The following is a description of a gene set: Genes up-regulated in peripheral blood mononuclear cells (PBMC) from patients with type 1 diabetes at the time of diagnosis versus those with type 2 diabetes at the time of diagnosis. Objective: We hypothesized that type 1 diabetes (T1D) is accompanied by changes in gene expression in peripheral blood mononuclear cells (PBMCs) due to dysregulation of adaptive and innate immunity, counterregulatory responses to immune dysregulation, insulin deficiency and hyperglycemia. Research Design and Methods: Microarray analysis was performed on PBMCs from 43 patients with newly diagnosed T1D, 12 patients with newly diagnosed type 2 diabetes (T2D) and 24 healthy controls. One and four month follow-up samples were obtained from 20 of the T1D patients. Results: Microarray analysis identified genes differing in expression between newlydiagnosed T1D patients and controls at a false discovery rate of 0.05. Changes in expression of interleukin-1β (IL1B), early growth response gene 3 (EGR3), and prostaglandin-endoperoxide synthase 2 (PTGS2) resolved within four months of insulin therapy and were also observed in T2D suggesting that they resulted from hyperglycemia. With use of a knowledge base, 81/genes could be placed within a network of interrelated genes with predicted functions including apoptosis and cell proliferation. IL1B and the MYC oncogene were the most highly-connected genes in the network. IL1B was highly overexpressed in both T1D and T2D, whereas MYC was dysregulated only in T1D. Conclusion: T1D and T2D likely share a final common pathway for beta cell dysfunction that includes secretion of interleukin-1β and prostaglandins by immune effector cells, exacerbating existing beta cell dysfunction, and causing further hyperglycemia. The results identify several targets for disease-modifying therapy of diabetes and potential biomarkers for monitoring treatment efficacy. studied in species Homo sapiens from publication Kaizer EC, Glaser CL, Chaussabel D, Banchereau J, Pascual V, White PC (PMID 17595242) Human Gene Set: GSE9006_TYPE_1_VS_TYPE_2_DIABETES_PBMC_AT_DX_UP, and this is the list of marker genes: RASGRP2, MRPS2, SPINT2, QTRT1, EDF1, NOC2L, TBL3, TSSC4, SAFB, IRF3, CCDC22, FUS (FUS RNA binding protein), FBXO41, RAB1B, HRAS, AURKAIP1, NELFB, CFDP1, SH3GLB2, ITPKB, ILKAP, PSMB10, TECR, TP53, ZNF512B, CLPTM1, VPS51, MED22, UBE2M, FOXK2, CNOT3, CD3E, LRRC41, CCDC85B, FABP5, STK25 (NCBI Gene Id 10494), RWDD1, GPS2, BRMS1, PTPRCAP, KLF13, ATP1A1, TRIM28, NADSYN1, CDK2AP2, COPS7B, AEBP1, RPS27, SNRPF, TLE5, RPL37, HTRA2, UCP2, APBA3, GATAD2A, AP5Z1, GCDH, WDR18, ST6GALNAC4, ATP13A1, LSM12, ARHGAP4, SIGIRR, PDAP1, PDCD4-AS1, SDF2L1, DAZAP1, PRPF31 (pre-mRNA processing factor 31), IMPDH2, AIP, SART1, CDC37, THAP7, RALGDS, NAA60, GSN, UBN1, GADD45GIP1, MFSD10, GTF2H4, TAF1C (TATA-box binding protein associated factor, RNA polymerase I subunit C), NFKBIB, HSPA9, WDR74, ERP29, SNF8, ERH, SMARCD2, PGLS, PEX5, POLD2, LIMD2, HNRNPK, SAFB2, RPLP2, PDIA3, MARCKSL1, SF3A2, ARHGEF1, ANAPC2, H2AX, SLC39A4, CFL1, LPCAT4, SLC2A4RG, TMEM259, ARF5, PIN1, TSR3, ATP5MC2, CNN2, MZB1, U2AF2, SIPA1, SSRP1 (NCBI Gene Id 6749), TAF4, PPIB, SRSF9, PAF1, TSPAN14, PFDN6, ABCF3, ANTKMT, RALY, PTPN6, PUF60, ATP2A3, COPG1, GFUS, ANXA6, VPS9D1, GZMM (granzyme M), PRR5, AMBRA1, DRAP1, PTMA, XAB2, BANF1, SNRNP70, CDK9, SLC25A22, CDCA4, TKT, ATP5F1D (NCBI Gene Id 513, ATP synthase F1 subunit delta), TACC3 (NCBI Gene Id 10460), AAMP, SLC7A5, CORO1A, TMED9, RPL36, RBM42, ABHD17A, EEF1D, PFDN2, NDUFC1, HNRNPA2B1, ARHGAP17, RRS1, ZBTB17, PRCC, PDLIM2, BBLN, HDHD5, E4F1, CD7, CCS, POLR2E, TAF10, NONO, SREBF1, DGKZ (NCBI Gene Id 8525), PRPF19, RPL11, EXOC7, SAC3D1, ARPC4, PTBP1, MTA1, TNFRSF14, YJU2, PPP6R2, DNAJC17, TRAPPC2, PDIA4, MRPL12, PEF1, PFN1, SF3B4, CD81, STARD3, OSBPL2, DNAJC7, HMG20B, UBE2S, ADRM1, DCAF15, HNRNPM, SRRM1, THOC6, LSM14A (LSM14A mRNA processing body assembly factor)